Given this list of marker genes DIPK2A, NUP153, GCLC, PHLPP2, OSGIN1, KDM7A, GK, XPO1, RAB8B, MACIR, TNPO1, JOSD1, SGMS2, CHIC2, ENTPD7 (NCBI Gene Id 57089), TULP3, GCLM, CNST, NPC1, PPP3R1, C10orf88, HMOX1, LCOR, ATXN7, KITLG, MOSMO, WHAMMP4, SLC7A1, LDLR, UNKL (unk like zinc finger), KLF4, HAPSTR1, NAV3, here is a description of the gene set: from publication Gargalovic PS, Imura M, Zhang B, Gharavi NM, Clark MJ, Pagnon J, Yang WP, He A, Truong A, Patel S, Nelson SF, Horvath S, Berliner JA, Kirchgessner TG, Lusis AJ (PMID 16912112) Genes from the yellow module which are up-regulated in HAEC cells (primary aortic endothelium) after exposure to the oxidized 1-palmitoyl-2-arachidonyl-sn-3-glycerophosphorylcholine (oxPAPC). studied in species Homo sapiens Human Gene Set: GARGALOVIC_RESPONSE_TO_OXIDIZED_PHOSPHOLIPIDS_YELLOW_UP Oxidized phospholipids are thought to promote atherogenesis by stimulating endothelial cells (ECs) to produce inflammatory cytokines, such as IL-8. In studies with mouse models, we previously demonstrated that genetic variation in inflammatory responses of endothelial cells to oxidized lipids contributes importantly to atherosclerosis susceptibility. We now show that similar variations occur in cultured aortic ECs derived from multiple heart transplant donors. These variations were stably maintained between passages and, thus, reflect either genetic or epigenetic regulatory differences. Expression array analysis of aortic EC cultures derived from 12 individuals revealed that >genes were regulated by oxidized phospholipids. We have used the observed variations in the sampled population to construct a gene coexpression network comprised of 15 modules of highly connected genes. We show that several identified modules are significantly enriched in genes for known pathways and confirm a module enriched for unfolded protein response (UPR) genes using siRNA and the UPR inducer tunicamycin. On the basis of the constructed network, we predicted that a gene of unknown function (MGC4504) present in the UPR module is a target for UPR transcriptional activator ATF4. Our data also indicate that IL-8 is present in the UPR module and is regulated, in part, by the UPR. We validate these by using siRNA. In conclusion, we show that interindividual variability can be used to group genes into pathways and predict gene-gene regulatory relationships, thus identifying targets potentially involved in susceptibility to common diseases such as atherosclerosis.